Given this list of marker genes C4BPA, VSIG4, CD55, MIR520B, PHB2, MASP1, C3, PHB1, CD46, A2M, C4BPB, SERPING1, CR1, CFH, MIR520E, CD5L, IL1B, SUSD4, C1QBP, CR2, CR1L, TREM2, CD59, here is a description of the gene set: Any process that modulates the frequency, rate or extent of complement activation. species: Homo sapiens Human Gene Set: GOBP_REGULATION_OF_COMPLEMENT_ACTIVATION